The following is a description of a gene set: Genes silenced by DNA methylation in bladder cancer cell lines. studied in species Homo sapiens from publication Wu G, Guo Z, Chang X, Kim MS, Nagpal JK, Liu J, Maki JM, Kivirikko KI, Ethier SP, Trink B, Sidransky D (PMID 17456585) Human Gene Set: WU_SILENCED_BY_METHYLATION_IN_BLADDER_CANCER Promoter hypermethylation is one of the common mechanisms leading to gene silencing in various human cancers. Using a combination of pharmacologic unmasking and microarray techniques, we identified 59 candidate hypermethylated genes, including LOXL1, a lysyl oxidase-like gene, in human bladder cancer cells. We further showed that LOXL1 and LOXL4 are commonly silenced genes in human bladder cancer cells, and this silence is predominantly related to promoter methylation. We also found LOXL1 and LOXL4 gene methylation and loss of expression in primary bladder tumors. In addition, somatic mutations were identified in LOXL4, but not in LOXL1 in bladder cancer. Moreover, reintroduction of LOXL1 and LOXL4 genes into human bladder cancer cells leads to a decrease of colony formation ability. Further studies indicated that the overexpression of LOXL1 and LOXL4 could antagonize Ras in activating the extracellular signal-regulated kinase (ERK) signaling pathway. Thus, our current study suggests for the first time that lysyl oxidase-like genes can act as tumor suppressor genes and exert their functions through the inhibition of the Ras/ERK signaling pathway in human bladder cancer., and this is the list of marker genes: PRKCD, CX3CR1, KLRC2, COL6A3, LRIG1, PLAAT4, HLA-DQB1, PTX3, CPE, COBL, PTPRC, COL5A2, PTGER3, ETV1, TSPAN8, ANPEP, GUCY1A1, NR4A1, SPINK1 (NCBI Gene Id 6690), CES2, ERBB3, NR4A3, ITGB2, MITF, FGL2, FCGRT, PXDN, JCHAIN, CNN1, SELENOP, CLIC2, HBB, TGFBR3, PLEK (pleckstrin), IGF1, UBL3, LMO2, PEG3, USH1C, PROM1, FMO5, LAMA2, VCAN, GATM, DPT, ZCCHC24, KLF4, SCRG1, MIR22HG, SLC4A4, MYH11, GCHFR